Given this list of marker genes HELZ2, ACTR8, NDRG1, DPCD, C11orf68, TIGD5, NCALD, ERAP1, PKIG, ITPKA, TSKS, PSD, LTA, PHIP, PPP1R15A, GLOD4, TLR4, HSP90AB1, POLD3, HLA-C, RPS5, DSCAM, AMHR2, POMP, PIK3R1, MRPL30, AAMDC, MTMR7, LSM10, SNW1, SCNM1, PSMB6, PPT2, ACOX2, PTS, SLC38A3, RMDN3, PLEKHF2, APTX, NFKBIE, TRIM21, ST6GALNAC4, METTL3, DDIT3, MAF1, SFT2D2, PRG3, STAT4, RAB22A (NCBI Gene Id 57403), HLA-DOA, ST3GAL1, LY75, KEAP1, PTCRA, PPP1R3A, USB1, ATP13A2, PMVK, AIDA, SEMA4D, ADORA2B, SYNGR2, MXD1, BLOC1S4, MX2, RNASE2, TOR3A, GNL1, ABCB1, CLCNKB, HPS3 (NCBI Gene Id 85393), CFAP20, HSD3B7, PSMA7, TEK, CABYR, ACAA2, ATP10A, PI4K2B, PLAT, TXNDC17, PLCL2, RNF135, BID, SLC25A22, SNAPC2, NUP62, TXNDC9, ENPP4, POLR1C, PCSK6, C8orf33, RGS9, MRPL4, TRIM54, RPS27L, CCNG2, CTTN, PVALB, RAB20, SCGN, BASP1, PMEPA1, C1QL1, TIMM13, SIX1, MAGI1, HNRNPH3, RNF115, PDE4DIP, ALCAM, BMI1, TSSK1B, BIRC2, MEFV, NUP50, REST, GHITM, FSCN1, SGCB, TAF1B, SAC3D1, IGBP1, MAP3K2, SHFL, PRPF38A, SMC5, SAMSN1, HIVEP2, KCTD14, CST3, KLHL10, LSP1, UBAP1, ASF1A (anti-silencing function 1A histone chaperone), FNBP4, METRNL, ELL2, HLA-DMB, RUSF1, TPRA1, ADHFE1, RAB12, FABP5, PFKFB3, SOCS2, ABHD16A (NCBI Gene Id 7920), SPG21, PIM1, GPR65, ALDH1A2, MRPL39, TCTE1, PSMB3, CCL2, SERPINC1, SLFN13, TSPYL1, IZUMO1R, SMPDL3A, P2RY12, RGS1, CACNG1, KLF1, BST2, IL12B, TRO, CCR7, EIF2AK2, RNF114, RNF19B, GATM, EBNA1BP2, RNF34, ZFP62, IFFO2, RBL1, KPNA3, APOOL, SYT12, FAM120A, TYK2, CHST7, TAGLN2, TCP10L, GSTM4, CARS1, ENTREP3, CLP1, TNFSF8, GLRX3, STAT3, IER5, BRD2, ISG15 (NCBI Gene Id 9636), DNMT3L, SPAG7, PIGH, DOK1, here is a description of the gene set: species: Homo sapiens from publication Amit I, Garber M, Chevrier N, Leite AP, Donner Y, Eisenhaure T, Guttman M, Grenier JK, Li W, Zuk O, Schubert LA, Birditt B, Shay T, Goren A, Zhang X, Smith Z, Deering R, McDonald RC, Cabili M, Bernstein BE, Rinn JL, Meissner A, Root DE, Hacohen N, Regev A (PMID 19729616) Human Gene Set: GSE17721_LPS_VS_GARDIQUIMOD_16H_BMDC_UP Genes up-regulated in comparison of dendritic cells (DC) stimulated with LPS (TLR4 agonist) at 16 h versus DC cells stimulated with Gardiquimod (TLR7 agonist) at 16 h. mouse primary BMDCs were stimulated with tlr ligands and gene expression changes were profiled on Affymetrix arrays